Given this list of marker genes Megf8, Dnah11, Ccdc39, Odad3, Dnaaf11, Rfx3, Invs, Ccdc40, Ofd1, Cfap45, Cfap53, Odad4, here is a description of the gene set: Mouse Gene Set: GOBP_EPITHELIAL_CILIUM_MOVEMENT_INVOLVED_IN_DETERMINATION_OF_LEFT_RIGHT_ASYMMETRY studied in species Mus musculus The movement of cilia of epithelial cells of the Left Right Organizer (LRO), also referred to as the node in mouse or the Kupffer's vesicle in zebrafish, resulting in the leftward fluid flow across the LRO and generation or transport of a signal which determines asymmetry in an organism's body plan with respect to the left and right halves.